The following is a description of a gene set: Genes up-regulated in HCT8/S11 cells (colon cancer) engineered to stably express NTN1 off a plasmid vector. from publication Rodrigues S, De Wever O, Bruyneel E, Rooney RJ, Gespach C (PMID 17334389) Deleted in colon cancer (DCC) and UNC5 function as netrin dependence receptors by inducing apoptosis in the absence of their ligand and accordingly were recently designated as putative conditional tumor suppressors. Herein, we determined whether netrin-1 and its receptors are implicated in cancer cell invasion and tumor progression. Expression of DCC, UNC5 and adenosine A2B-receptors (A2B-Rs) was investigated by reverse transcription polymerase chain reaction in human colon cancer cells. The impact of DCC restitution and netrin-1 was evaluated on collagen type I invasion, tumor growth and metastasis in nude mice, cancer cell survival and gene expression profiling. Flow cytometry, poly(ADP-ribose)polymerase-1 and caspase-8 activation were used to evaluate the impact of DCC on cell death. Both netrin-1 and A2B-R activation induced the invasive phenotype through the Rho-Rho kinase axis in DCC-deficient human colorectal cancer cells. Restitution of wild-type DCC blocked invasion induced by netrin-1, A2B-R agonist and other agents. Ectopic expression of netrin-1 led to increased growth of human colon tumor xenografts in athymic mice. Conversely, introduction of wt-DCC in kidney MDCKts.src-ggl cells strongly inhibited metastasis in lymph nodes and lungs and increased sensitivity to apoptosis in hypoxia. DNA microarrays revealed that netrin and DCC had common and divergent impacts on gene expression linked to cell cycle, survival, surface signaling and adhesion. Our findings underscore that netrin is a potent invasion and tumor growth-promoting agent and that DCC is a metastasis suppressor gene targeting both proinvasive and survival pathways in a cumulative manner. Human Gene Set: RODRIGUES_NTN1_TARGETS_UP species: Homo sapiens, and this is the list of marker genes: NRXN3, SH3BGRL, SATB2, HOXD10, SOCS2, TOX3, LEF1, PCDHB14 (NCBI Gene Id 56122), FHOD3, PXN-AS1, RDX, BDNF, KITLG, PLXNC1, FBXO11 (F-box protein 11), HMGN5, NFIB